The following is a description of a gene set: Human Gene Set: GOBP_ATRIOVENTRICULAR_VALVE_FORMATION species: Homo sapiens The developmental process pertaining to the initial formation of the atrioventricular valve from unspecified parts. This process begins with the specific processes that contribute to the appearance of the discrete structure and ends when the structural rudiment is recognizable., and this is the list of marker genes: HEY2, SMAD4, NOTCH1, GATA4, DCHS1, OLFM1, HEY1, ZFPM1